The following is a description of a gene set: Genes up-regulated in CD4 T cells stimulated with allergen (house dust mite): atopy versus healthy. species: Homo sapiens The aim of this study was to employ a systems-level analysis to elucidate gene expression networks operating in the CD4 T-cell responses which underpin human atopic disease. from publication Bosco A, McKenna KL, Firth MJ, Sly PD, Holt PG (PMID 19414752) Human Gene Set: GSE14908_ATOPIC_VS_NONATOPIC_PATIENT_HDM_STIM_CD4_TCELL_UP, and this is the list of marker genes: PIGM, NMNAT1, MGLL, NDUFS3 (NADH:ubiquinone oxidoreductase core subunit S3), CLASP1, GSS, STAU2, SLC7A5, GNE, THAP12, C8orf33, TMX1, IL2 (interleukin 2), PCBP1, TCP10L, DMAP1, MAPK3, COQ8B, IQCC, PTPN9, INHA, SPRED1, TOMM40L, C15orf40, FBXW11, PI4K2B (NCBI Gene Id 55300), C9orf40, HAUS5, AKR1C3, PHACTR2, TSEN34, TMEM161A, SMIM11, PRIMA1, COA6, EIF2B5, FANCG, CTNNBIP1, PBDC1, SNX10, RBBP7, ITGB1BP2, FAHD1, CHST2, E2F3, POLR3A, SMDT1, CDYL, GLRX3, SARNP, RTN3, APTX, GSTM3, NCBP3, WDR6, STT3A, ARPC3, PLCB3, RXYLT1, SIGIRR, DPP8, OMA1, HDAC3, IDH1, TMEM163, EMC7, PLBD2, H2BC5, RNF121, CHID1, HIVEP3, NCAPH2, SAC3D1, MATN4, SEM1, CEP15, CXCR6, GPR65 (NCBI Gene Id 8477), POLH, ELAVL1, PARS2, TNFRSF9, TUBD1, CHM, PRPS1, KCNN4, YAE1 (YAE1 maturation factor of ABCE1), NEFH, BABAM1, SSBP1, PLIN2, PPP2R3C, CPNE3, RAP1A, TSR2, MTDH, SNRPB2, ST14, PSPH, ZCCHC10, LGALS2, CASKIN2, KCNAB2, RAD9A, TUBA3C, SLC37A2, C1D, TEX9 (testis expressed 9), AATF, GATM, ANGPTL2, GATAD2A (NCBI Gene Id 54815), MAB21L2, NSMCE2, RYK, ERCC1 (NCBI Gene Id 2067), OARD1, NIT1, ARL14EP, CENPB, CCL4, ZMAT3, EI24, IDH3B, NCF4, UQCRC2, EIF5B, MRPL41, HTT, GNPTAB, BAG4, EIF3A, MYO10, SRP54, SPIDR, PEMT, KPNA6, CA13, SEPTIN7, TBC1D24, GAS2, LYRM2, RBM28, TMEM223, DHX32, NFU1, LSS, BCDIN3D, NDUFB5, EDEM2, SURF4, CYB5A, COPS8, LZTR1 (leucine zipper like post translational regulator 1), GPR89B, RPP25L, NLGN2, DNAJB11, RCAN1, CBX6, NSDHL, NDUFA11, SNRPG, ACSBG1, FAM149B1, DDB1, TBC1D19, NR2F6, ESD, BLMH (NCBI Gene Id 642), CEMIP2, MLLT1, SLC25A47, GOLGA7, ITGB1, SURF2, MTAP, TXNDC5, ALDH9A1, UTP25, KDELR1, RPS2, AKT3, BBLN, RPL24, EFCAB2 (NCBI Gene Id 84288), GNA15, POLK, ANXA3, ATP10A, PFN1, TMEM39A, ODF2L, DEK, PDF, VAMP8, NUFIP1, COX6A1, CBX1, TMEM101